The following is a description of a gene set: Biosynthesis of the N-glycan precursor (dolichol lipid-linked oligosaccharide, LLO) and transfer to a nascent protein Human Gene Set: REACTOME_BIOSYNTHESIS_OF_THE_N_GLYCAN_PRECURSOR_DOLICHOL_LIPID_LINKED_OLIGOSACCHARIDE_LLO_AND_TRANSFER_TO_A_NASCENT_PROTEIN studied in species Homo sapiens, and this is the list of marker genes: NEU3, ST8SIA1, DPM3, ALG9, ALG8, DOLPP1, DPM2, NEU2, ALG11, GLB1, ALG12, PMM2, GMPPB, FUOM, MPI, AMDHD2, ALG13, NEU1, ST6GALNAC2, UAP1, ST3GAL6, DHRSX, ST3GAL1, ALG6, ST8SIA3, ST6GALNAC4, ST3GAL3, GFPT1, SLC35C1, GMDS, ST8SIA4, DPM1, ST8SIA6, DHDDS, FCSK, DOLK (dolichol kinase), GNE, SLC17A5, ST8SIA2, NUS1, ST3GAL5, GMPPA, GFPT2, ALG5, ST3GAL4, ST3GAL2, NAGK, CMAS, ALG2, ST6GALNAC1, NANS, PMM1 (phosphomannomutase 1), FPGT, NPL, ALG1, ST6GALNAC3, DPAGT1, HK1, GFUS, NUDT14, ST6GALNAC5, MPDU1, CTSA, PGM3, ST6GAL1, ALG10, RENBP, GNPNAT1, NEU4, ALG3, ALG10B, ST6GALNAC6, SRD5A3, MVD, ALG14, RFT1, ST6GAL2, ST8SIA5, NANP, SLC35A1